The following is a description of a gene set: studied in species Mus musculus from publication Chen Y, Wang X (PMID 31504780) Mouse Gene Set: MIR_883A_3P_MIR_883B_3P Genes predicted to be targets of miRBase v22 microRNA mmu_miR_883a_3p, mmu_miR_883b_3p in miRDB v6.0 with MirTarget v4 prediction scores > 80 (high confidence targets)., and this is the list of marker genes: Rbbp6, Ptprk, Hectd1 (NCBI Gene Id 320157), Stxbp6, Hnrnpl, Ltb4r2, Usp38, Pcna, Tshz3, Cxxc4, Zbtb44, Kmt2e, Tll1, Kctd5, Dicer1, Hnrnpll, Tsg101, Nfia, Yaf2, Vezf1, Atl2, Asph, Cul2, Ptgfr, Dhx15, Gmfb, Foxa1, Pax3, Trip13, Wnt3, Clstn1, Ube2l3, Thap1 (NCBI Gene Id 73754), Usf3, Pten, Chrdl1, Loxl2, Phospho1, Zc3h4, Ubr1, Fhl1, Ywhab, Hspb8, Fga, Opa1, Zfp654, Lrrc4b, Nkrf, Fdx1, Rhoj, Luc7l3, Chordc1, Spart, Cept1, Canx, Hipk1, Als2, Optc, Tmf1, Sod2, Adgrg2, Rbm33, Zbtb21, Fsd2, Tpbg, Stt3a, Nhlh2, Tshz1, Kdm3a, Ap4e1, Sars1, Casp2, Qrsl1, Ddx4, Suz12, Tnks, Etfrf1, Gng11, Hmga1b, Aak1, Ckap4, Gapt, Lrch2, Msl3l2, Tstd2, Slu7, Zkscan8, Nfkbie, Zfp131, Itih2, Rictor, Zfand6, Ctsc, Nr2c1, Spin4 (NCBI Gene Id 270624), Gls, Srsf10, Hnrnpu, Agtr2, Grk4 (NCBI Gene Id 80675), Kcna4, Tmem236, Adgrb3, Yipf4, Akap11, Stmn2, Nup188, Nol7, Hivep3, Alg10b, Srsf1, Zeb1, Cdk13, Tbcel, E2f6, Hcrtr2 (NCBI Gene Id 387285), Fgf14, Nr4a2, Rapgef6, Acad8, Vdac2, Kera, Rest, Eif4g3, Ctbp2, Fank1, Slf2, Tet2, Zdhhc21, Hmga1